Given this list of marker genes Emilin1, Jak2, Htr2a, Ank3, Emilin2 (NCBI Gene Id 246707), Ctsg, Lgals1, Plaur, Tnfsf11, Ccl5, Jak1, Il6, Il6ra, Mfsd2b, Mmrn1 (multimerin 1), F11r, Pdpn (podoplanin), here is a description of the gene set: Any process that activates or increases the frequency, rate, or extent of homotypic cell-cell adhesion. species: Mus musculus Mouse Gene Set: GOBP_POSITIVE_REGULATION_OF_HOMOTYPIC_CELL_CELL_ADHESION